Given this list of marker genes SOCS3, OR5L2, ZNF169, PADI3, LMNA, NRG1, HBM, HBZ, CREB5, ATAD3C, OPTC, UTS2R, SYNM, FRMD1, PROX1-AS1, PCDHGB8P, ICAM1, MALT1, SRPK3, PRAP1, ADAMTSL5, ETV3, MYO1H, ARHGAP20, FIGLA, KRT3, DIPK1B, CNTF, PHF21B, TSPAN10, PDGFA, PCDHGB6, CFAP206, FBXO24, DUSP4 (dual specificity phosphatase 4), TPSG1, CSPG4, NFYC-AS1, AQP2, CEP104, DAPL1, LINC00265, BALR6, CCDC70, DBH, USP12, CALR3, LINC00161, PAX3, ANO8, TMEM204, TNFRSF14-AS1, FGF22, ARFGAP3, RNASE11-AS1, HMHB1, ACACB, LRP12, GARIN5A, GPR132, OXCT2, AMZ1, DCD, FOXN3-AS1, ATP2B2, CCR10, ID4, RARB, TCP11L2, TMEM254-AS1, JMJD6, PHOX2B, INSIG1, TNFRSF25, SH2D1A, GPR78, CD80, KLK4, TEX22, MAPK8IP2, TULP1, ZMIZ1, CASR, H4C9 (H4 clustered histone 9), PROP1, NDUFA10, SFRP1, DUOXA1, NEUROG3, NTN3, PIM3, DOC2A, GUCA2B, MYOZ3, BCL6B, CAMKK1 (NCBI Gene Id 84254), ATP2B3 (NCBI Gene Id 492), H1-1, SLC2A3, FLYWCH2, AGO2, NECAB2, PPY, CYP2B6, EOLA2-DT, DPM1, POLN, PCDHGA3, AMPH, SPATA31C2, TRAV12-2, STUB1-DT (NCBI Gene Id 84763), HBQ1, ACP4, TNFAIP8, NUP98, FOXG1, TMEM179, PTPRG (NCBI Gene Id 5793), SPATA31F1, TRIM42, ZNF189, GPR183, TRPC2, KIF12, FETUB, FAM181B, LY6D, TBC1D28, IGLV4-3, TBX2, H2BW2, PKP2, SELENOK, JUN, ZNF653, LINC02239, MISP, PLEKHF1, COX6B2, RASSF5 (Ras association domain family member 5), NRXN3, ESPL1, PTGDR2, NYX, C4BPA, HAND2, RET, ZRANB2-AS1, PPY2P, UBE2QL1, HBEGF, LPAR3, JSRP1, MID2, KCNA4, TRIM61, PRAMEF10, ANGPTL8, ZNF395, CNN1, PRDM8, PLIN1, ANO7L1, LMNTD2, CCDC177, PRMT8, LY6E-DT, ZNF341, PPP1R15A, ADGRG1, GRIK4, KLHDC7A, KIR3DX1, PANX2, KY (kyphoscoliosis peptidase), KRT75, LINC02685, CDH13, UBTD2, ANO1, KRT19, here is a description of the gene set: Genes down-regulated in CD8 T cells: STAT1 knockout versus STAT4 knockout. from publication Gil MP, Ploquin MJ, Watford WT, Lee SH, Kim K, Wang X, Kanno Y, O'Shea JJ, Biron CA (PMID 22968462) Type 1 IFNs can conditionally activate all of the signal transducers and activators of transcription molecules (STATs), including STAT4. The best-characterized signaling pathways use STAT1, however, and type 1 IFN inhibition of cell proliferation is STAT1 dependent. We report that type 1 IFNs can basally stimulate STAT1- and STAT4- dependent effects in CD8 T cells, but that CD8 T cells responding to infections of mice with lymphocytic choriomenigitis virus have elevated STAT4 and lower STAT1 expression with significant consequences for modifying the effects of type 1 IFN exposure. The phenotype was associated with preferential type 1 IFN activation of STAT4 as compared to STAT1. Stimulation through the TCR induced elevated STAT4 expression, and STAT4 was required for peak expansion of antigen-specific CD8 T cells, low STAT1 levels, and resistance to type 1 IFN-mediated inhibition of proliferation. Thus, a mechanism is discovered for regulating the consequences of type 1 IFN exposure in CD8 T cells, with STAT4 acting as a key molecule in driving optimal antigen-specific responses and overcoming STAT1-dependent inhibition of proliferation. studied in species Homo sapiens Human Gene Set: GSE40666_STAT1_KO_VS_STAT4_KO_CD8_TCELL_DN